The following is a description of a gene set: The developmentally regulated remodeling of neuronal projections such as pruning to eliminate the extra dendrites and axons projections set up in early stages of nervous system development. Mouse Gene Set: GOBP_NEURON_REMODELING species: Mus musculus, and this is the list of marker genes: Farp2, Bcl11a, Abl2, Scarf1, Ntn4, App, Epha8, Anks1, Cspg4, Pdgfb, Adgrb3, C1qa, Rnd1, C3, C1ql1, Kcnq3, Kcnq2, Gnaq, Ednra